Given this list of marker genes GRIN1, SIK1, GRM7, SCN1B, PNKP, CDKL5, PIGQ, DMXL2, NEUROD2, CASK, SCN2A, KCNA1, ARX, TRIM8, SLC32A1, SLC25A22 (NCBI Gene Id 79751), KCNH1 (NCBI Gene Id 8656), PIGP, GNAO1, ATP6V1B2, here is a description of the gene set: Absence of thumb nail. Human Gene Set: HP_ABSENT_THUMBNAIL species: Homo sapiens Absent thumbnail